Given this list of marker genes LBR, PLOD3, LIFR, B3GLCT, SALL4, ABCC9, KIF22, ATR, ERI1, RSPRY1, ROR2, SHOX, ALDH18A1, CSGALNACT1, PTPN11, ASXL1, OPA3, DMD, MYH3, FGFR3, ATP7A, LAMA2, TAF4, LTBP3, SFRP4, SCN4A, FKBP10, SPRED2, TPM2, SMC1A, RNU4ATAC, IFITM5, MED12, BANF1, ERCC6, EXTL3, PYCR1, TMEM222, RSPO2, B3GAT3, TRAPPC2, BGN, SLC6A9, GNB2, SLC26A2, LMNA, ERGIC1, UBA1, FGFR2, CRLF1, CAPN3, ANO5, MATN3, CHST3, MET, TMEM43, ECEL1, DYM, SF3B4, SPRTN, FBN2, PTH1R, SMAD6, RAB33B, LARGE1, SCYL2, PIGY, GLDN, LMX1B, COL6A2, HACD1, SELENON, GNB1, KCNK9, FLNA, NIPBL (NCBI Gene Id 25836), TBX3, WNT7A, MYL1, HDAC8, SVIL, GJB2, LGI4, PTDSS1, COL9A3, PLOD1, WNT5A, COL25A1, ITGA7, RMRP, PLOD2, PPP2R3C, RECQL4, MMP13, TOR1A, COLEC10, COL6A1, NALCN, PCNT, TBX15, PIGA, POR, HRAS, HOXA11, FBXO28, SNRPB, COLEC11, MYL11, TONSL, PIK3C2A, TPM3, B3GALT6, ITCH, DYSF (NCBI Gene Id 8291), P4HTM, JAG2, ERCC1, TBX5, SCARF2, MASP1, SYNE2 (spectrin repeat containing nuclear envelope protein 2), COL27A1, COL12A1, FZD2, ERLIN2, MAPK1, EMD, MYOT, DVL1, PSTPIP1, SLC25A46, UNC80, COL2A1, FLNB, KY, EZH2, STAG1, FHL1, GNS, FILIP1, MYL2, CPT2, HS2ST1, STXBP1, SLC29A3, NPR2, MAP3K7, FDFT1, SYT2, PSMB8, TDO2, CLCF1, COL6A3, TRPV4, TFE3, FBN1, COMP, TFAP2A, MAP3K20, SMC3, BPNT2, ACTA1, ESCO2, SYNE1, SLC39A8, DDR2, GPC6, MECOM, here is a description of the gene set: species: Homo sapiens Limited elbow movement Human Gene Set: HP_LIMITED_ELBOW_MOVEMENT